The following is a description of a gene set: Mouse Gene Set: GOBP_TRANSCRIPTION_INITIATION_AT_MITOCHONDRIAL_PROMOTER A transcription initiation process that takes place at a promoter on the mitochondrial chromosome. studied in species Mus musculus, and this is the list of marker genes: Tfb2m, Polrmt, Tfam, Tfb1m, Mterf1b